Given this list of marker genes GRN, HAVCR2, KLK7, SIGLEC16, EMILIN2, EMILIN1, KLK3, CYBA, F2RL1, MMRN2, KLK5, PGC, NLRP10, here is a description of the gene set: species: Homo sapiens Human Gene Set: GOBP_POSITIVE_REGULATION_OF_DEFENSE_RESPONSE_TO_BACTERIUM Any process that activates or increases the frequency, rate or extent of defense response to bacterium.